The following is a description of a gene set: species: Homo sapiens Human Gene Set: GOBP_RENAL_SYSTEM_PROCESS_INVOLVED_IN_REGULATION_OF_BLOOD_VOLUME A slow mechanism of blood pressure regulation that responds to changes in pressure resulting from fluid and salt intake by modulating the quantity of blood in the circulatory system., and this is the list of marker genes: GJA5, ADORA1, F2R, CORO2B, HSD11B2, PTPRO, CYP4A11, PDGFB (NCBI Gene Id 5155), CYBA, CYP4F12, TTR, CYP4F2, GAS6, EMP2 (epithelial membrane protein 2), CYP11B2, F2RL1